The following is a description of a gene set: The directed movement of L-arginine from outside of a cell, across the plasma membrane and into the cytosol. studied in species Homo sapiens Human Gene Set: GOBP_L_ARGININE_IMPORT_ACROSS_PLASMA_MEMBRANE, and this is the list of marker genes: SLC7A1, SLC7A3, SLC47A1, SLC22A2, SLC7A2